The following is a description of a gene set: from publication Yevshin I, Sharipov R, Kolmykov S, Kondrakhin Y, Kolpakov F (PMID 30445619) Genes containing one or more binding sites for (E2F2) in their promoter regions (TSS -1000,+100 bp) as identified by GTRD version 20.06 ChIP-seq harmonization. species: Homo sapiens Human Gene Set: E2F2_TARGET_GENES, and this is the list of marker genes: PRRG2, OXSR1 (oxidative stress responsive kinase 1), KPNB1, METTL8, GANC, SAC3D1, SH3BP5L, COPS4, TOP2A, SNHG32, ITPRIPL2, CENPN, SNIP1, ELAC2, IMP3 (NCBI Gene Id 64970), KIF18A, CHMP7, MRM2, METTL2B, ELP5, PURB, MAP3K6, MAP3K11, SMC5, NCLN, NSL1, BTD, HRH1, EPM2AIP1, TNFRSF10A-DT, SIRT2, CLN3, B4GAT1, FGFR4 (NCBI Gene Id 2264), BCL3, SLC24A1, CACNA2D4, CSTF2T, HEPH, TLDC2, GNB2, SPATA41, UTS2B, RSRC2, PLEKHA6, UBE2B, USP37, TOMM20L-DT, SIL1, RNPEP, CASP8AP2, SEC31A, CDCA7L (NCBI Gene Id 55536), RPS6, PNISR, VTRNA1-2, DYNC2I1, MPZL3, RIMKLB, NIF3L1, NOL12, PAK4, ZNHIT2, FBXO33, MAST3-AS1, LRRC1, MLEC, AKT2, GLI1, CSNK1G3, ANK3, PRR5L, ALDH4A1, SNHG10, DCLRE1C, PPP2R1B, RPS12, ZNF747, HMGB2, RDM1P5, RPRD1B, EXOSC7, TSNAX, CDK1, NAA40, QRICH1, IRGQ, SIDT2, ATAD2, UQCC2, TUT1, SPRED2, SLC28A2-AS1, DDX41, C2CD3, TMPO, POLR1B, SPAG16-DT, RAB11B, HDGFL2, MFSD4B, TRAPPC9, DHPS, SYNGR4, GINS3, DDX39A, MSL1, CCDC47, UBXN8, INTS7, EDEM3, ATP10B, COMMD6, NOL8, BORCS8-MEF2B, TMC1, SRP54-AS1, GFM1, RNFT2, CDKL3, SH3BGRL3, TMA16, PDE8A, PPP1R11, HINT3, PLBD1, BAZ1B, RBBP4, ZMYM6, VTA1, CACTIN, CCNA2, DDX39B-AS1, CLSPN, ERP29, ACSS2 (acyl-CoA synthetase short chain family member 2), MKNK1, YARS2, RBBP5, CHAC1, TOP6BL, PSME2P3, CDH17, KAZALD1, CEP112, C6orf141 (chromosome 6 open reading frame 141), TMBIM6, CPEB4, RPL7L1P8, LSR, SRI, SLC25A23, CUTC, INPP5J, SNHG1, HACD2, MCM6, RPL26L1, POP7, TCF3, DDX11, FEM1A, MRPS31P4, TRIP4, RNF186-AS1, TRIM35, FASTKD5, SLC9A1, ABHD10 (abhydrolase domain containing 10, depalmitoylase), UBE2M, MCM5, DDIAS, HNRNPD, FTX, POLR2K, RBM14-RBM4, ASF1B, COX16, ZSCAN9, GAS2L1, UBL5, LINC00479, C19orf48P, CWC27, RGL2, BAHCC1, ANKHD1, MTMR9, SATB2, VPS72 (vacuolar protein sorting 72 homolog), HRCT1, LIM2-AS1, CEP63, NUTM1, FOXD1, ALKBH2, RFWD3, NR4A2, TSG101, POLR2M, RC3H2, RNASEK, PPP3CB, E2F2, ATF7, SEPTIN7-DT, GIRGL, NCAPG2, TDG, RPS7, CDIPT, TMC3-AS1, SLC4A1AP, B9D1, LRRC14, IDH3A, TNPO3, RWDD1, YAE1, OAS1, KBTBD4, PISD, TMEM79, THAP9, H2AZ2, CHCHD3, GAPDHP25, RPS25, AHCYL1, CDIPTOSP, NUP85, VPS33B-DT, IDH1, OGA, ARHGAP5, SYNCRIP, ZNF592, BRAT1, RPL21, TM4SF4, THAP9-AS1, PEF1, CMC2, SLC39A9, PSMD1, SNX8, TRAPPC4, PRPF40B (pre-mRNA processing factor 40 homolog B), BANF1, FBXO24, CCDC9, ETFBKMT, MPIG6B, NDC1, ITSN1, CKAP2-DT, RPL28, DCAF17, PDK2, OXA1L, ERH, FANCD2, MIGA2, STAM2 (signal transducing adaptor molecule 2), NUBPL, KLHL7, TICRR, AHRR, COQ6, GPRC5C, DPAGT1, TADA3, ZNF644, GOSR2, BRI3BP, SPC25, NSA2, SPATS2L, EIF3H, SPAG16, RPS6KA1, PHF14, PTPRZ1, RAB11A, IQCK, PROSER3, SUB1, MFAP3L, GON4L, TPM3, CHD9NB, DPH3, LTN1, CBY1, TMEM209 (NCBI Gene Id 84928), IMMP1LP1, HIBCH, ATR, TAF6L, CDKN2D (cyclin dependent kinase inhibitor 2D), EFNA3, C12orf76, PIK3C3, PXN-AS1, SLC2A8, GGA1, PIGW, BUB1B, EED, GABPA, EPCAM, SEMA3C, CLCF1, EME1, NCDN, DMRT2, GORAB-AS1, ING3, PTPN23, BRIX1, HSPB6, STAMBP, RCAN1 (regulator of calcineurin 1), PTBP1, SLC7A7, ZFAND6, PXMP2 (NCBI Gene Id 5827), ETV6, PRR11, ADAM9, H2AC15, LARP4, ARL6IP1, MIR3912, NFATC2IP, MCM4, SMIM31, TRBV30 (NCBI Gene Id 28557), SMG5, INTS2, PABIR1, GOLT1B, MYO15B, PBX1, HDGF, DNM1L, FAM156A, EXOSC2, PHLDA1-DT, CDK5RAP3, ELP6 (NCBI Gene Id 54859), MRPL17, WDR37 (WD repeat domain 37), RFXANK, RFC4, EWSR1, ZNF701, KIFC1, AKR1B10, DDX12P, DLG2, RNF39, BCL7B, MRTFA, KCNG3, PITX2, NUF2, TARS1-DT, RPS14, CCDC28A, TNFAIP8, RBM47, RIC8A, ENSG00000271860, MIX23, TMEM87A, NUBPL-DT (NCBI Gene Id 105370437), TLCD4, CSTF3, NVL, ROCK2, RIN1, ANP32E, ZNF213, HEXIM1, CENPE, YJU2, TMEM97 (NCBI Gene Id 27346), BRD8, ERI2, THG1L, TEX261, CEP295, PPP3CB-AS1, TCP11L2, TRA2B, RIF1, CLSTN1, POC1B-GALNT4, SLC35B1, LINC00339, ATM, RNU6ATAC, CSNK1D, SLC39A13, TSNAX-DISC1, BIN1, ZNF584, PPCDC, ZNF384, MIR4999, TNFRSF10B, MCFD2, DNAJC25, DLST, ZNF503, POU2F3, JUP (junction plakoglobin), MTMR9LP, NDRG1, CTDNEP1, LONP1, TPRA1, CENPF, SUPT5H, AP3S2, PHLDA1, HOXA-AS3, NPAT, SNORD26, AP4S1, PRR15, TXK, SLBP (stem-loop histone mRNA binding protein), TMEM126B, AIFM1, NDUFS3, PCLAF, DESI1, NIFK-AS1, NUMA1, TSLP, RPGRIP1L, LIPE-AS1, PJA2, TBL1X, TNRC6B, PANK3, TANK, FBXL5, C3orf38, LIPE, TOMM20L, MIA3 (NCBI Gene Id 440718), PPP4R3B, PPIG, NWD1, ARFIP1, CEP57L1, ACTMAP, MPP7-DT, NDUFA2, CASP7, UBE2I, NPRL2, SEC16B, NR2C2, LTBP1, POLR2B, HYAL2, RAD1, CIDECP1, PEF1-AS1, TTC1, AFF1, TIMM8A, UTP18, LINC01635, GTF2A1, LMAN2, PET100, SEPTIN7, SLC3A2, YWHAG, FTO, EMG1, HEG1, MCM7, AP3B1, GRIPAP1, RAF1, ZBTB22, LDHA, PPME1, PIGB, ARL14, HMGN1, IFT52, LGALS4, PIAS1, RN7SL346P, SUGP1, CYP2S1, POLD3, GINS1, CYRIB (NCBI Gene Id 51571), PHB2, GLIPR1L2, TBL1XR1, POT1-AS1, FRAT1 (FRAT regulator of WNT signaling pathway 1), MRPL27, STAG3L5P-PVRIG2P-PILRB, CEP97, FLCN, EHD2, EHD1, RPL10P15, KCTD20, HMBS, CDK12, H2AX, SMC2, TNFRSF10A, FAM174B, MRPL45P2, MED28-DT, DYNLRB2-AS1, ATL2 (NCBI Gene Id 64225), DUT, RNF128, ESF1, RPS26, TBC1D15, CCDC28A-AS1 (NCBI Gene Id 100507462), ENSG00000293341, ZCCHC8, KIAA0319L, VRK3, UBAP2L (ubiquitin associated protein 2 like), SP110, ARPC4-TTLL3, KIF3A, DPP3, QPCTL, PIN4, MED23, RAD54L, NUP42, ZNF747-DT, CAP2, SARM1, AKAP11, UQCR11, BET1L, RN7SK, COX7A2L, POLR3A, SCAMP1, PRCC, SP2-AS1, MTMR4, SPRY4, MLLT3, DUS4L, TMEM165, SRP54, EPB41L4A-AS1, MYO1A, CCNB1, AAGAB, RPL35, MDC1, RDH13, DBT, RBM15, MAT2B, TTC23, ENSG00000259182, ZNF799, ZNF687, GORAB, GDPGP1, COQ8B, EFHC1, C6orf52, STK31, MKKS, SLC30A4-AS1, VTRNA1-1, RYR3, SEMA4B, BCAS3, GRHL2, LRP4-AS1, MIR638, TMPRSS4, KRR1, SPC24, LINC03011, ZFYVE26, PRKCI, TTC13, NUDT9, MMS22L, LRRC23, MLH1, ARV1, DDX39B, MCM8, PDCD4, SFXN5, KIF20A, PFKM, UBL7-DT, LINC02756, IFT56, B4GAT1-DT, SUPT7L, RIOK3, EPCAM-DT, DOHH, EMC1-AS1, COX6B1, EVPL, DNAJC25-GNG10, FAM114A2, ALG14, TMX1, TBCCD1, MZT1, DHX34 (NCBI Gene Id 9704), RPL19, PTGES3, CDKN2C, SMG8, CLDN12, ARHGAP32, CDK5RAP2, HOMER1, LINC02205, RAD52, DTL, CNTRL, SERTAD1, NOP10, MYLK-AS1 (NCBI Gene Id 100873940), LAMA3, XAB2, SLC30A10, NCOA2, HTATSF1P2, CFAP20, DENND5B-AS1, ENSG00000239137 (novel transcript), AOC1, PCNX3, GCDH, RRM1, ATP5ME, CELSR3 (NCBI Gene Id 1951), JADE2, SNX1, CIMIP5, FAM200B, GOSR2-DT, DCTN1, PPP6R1, FBXL12, H4C4, OIP5-AS1 (OIP5 antisense RNA 1), CLPTM1, IPP, ATP8A1, EPG5, UBOX5, VPS50 (VPS50 subunit of EARP/GARPII complex), GMEB1, APOLD1, MED18, DCP2, REXO4 (REX4 homolog, 3'-5' exonuclease), HMGXB3, CCNI, LBR, RPLP0, NOSIP, NAP1L4, CD320, NUCKS1, TM2D1, BZW1, PKP3, SLC22A5, UBL7, LEMD3, RNF44, PSME3, PIK3R3, STXBP1, WASL-DT, ASB16-AS1, COL7A1, FDXR, CDC6, PIK3C2B, RSBN1, ZNF106, RPS29, RHEB, ADGRL1-AS1, GTF3C2-AS2, PEX16, LIMA1, MTMR14, SYT8, SREBF2, PPID, CDON, WDR36 (NCBI Gene Id 574015), TMT1A, RCHY1, BTBD10, FBXO9, RPS16, LINC01275, LRRC41, PPIC, CCNJL, SELENOW, COX15, BTBD19, ATF7-NPFF, ATP8A1-DT, MCTP2 (multiple C2 and transmembrane domain containing 2), GALE, GTPBP3, FCF1, TMC4, SLC36A1 (solute carrier family 36 member 1), COL4A2, RPL5, POLG-DT, FBXW7, CPOX, CCDC18-AS1, SNORA13, SSBP1, FRMD4B, SRRM5, ILK, TMEM167B, RHBDD3, MMAB, ELK4, H2AZ2-DT, EID1, XRCC6, HACD1, PRKRIP1, WASF2, PABPN1, MIA2-AS1, PPFIBP2, RGS20, EIF2S2, TLCD4-RWDD3 (TLCD4-RWDD3 readthrough), KCNIP2-AS1, XPO1, RPS9, ENPP3, FGD5-AS1, CRKL, KNTC1, LINC02615, LINC01431, ARPC4, HMGN2P46, NAXE, IGF2BP3, CGGBP1, ANKMY2, USF3, ZNF785, ATXN2, CENPT (NCBI Gene Id 80152), PPP1R37, NR5A2, GTF2A2, TRMT6, TARS1 (NCBI Gene Id 94887), UNC5B-AS1, PPM1L, CASD1, ILF3, BORCS8, NUP98, EIF2B5, HADHB, COPS5, MGME1, DNAJB11, RBM15-AS1, PLA2G6, ODAD3, RPAP1, LPCAT4, MAPK14, ZNF79, U2AF2, AP2S1, PIGBOS1, RGL1, PCLO, PCM1, KIF11, UQCC6, DYNLRB2, MIR3124, SNORA70, CSPP1, PRR7, TPI1P2, SKP1, SPTLC3, KPNB1-DT, PKP2 (plakophilin 2), PIBF1, AATF, ANKHD1-DT, METTL15, NAV1, PTPN21, ATOSB, GSTA4, RNU2-17P, MAP3K14, LINC00112, MRPL51, CLIP1, VPS4B, VARS2, BTAF1, SAE1, SELENOP, MYO19, CENPK, NUDT1, TMEM144, STAG3L5P, CEP120, EFCAB7, FBXO5, ANXA2, CRYZL1, SH2B1, USP36 (NCBI Gene Id 80160), METTL1, PHPT1, ZNF576, DIS3, NRP1, ARL1, PRPF4, COX5A, PLEK2, SHC4, ACO2, HSPA13, XPNPEP1, ENSG00000259403, ENC1, AP1M1, ANAPC13, MIA2, SMARCAL1, TRUB2, KRT8, OXA1L-DT, DNAAF3, ZNF271P, HNRNPD-DT, DDX3X, NKTR, OR10J2P, SRSF1, AURKB, NFKBIZ, ADAM11, DYNLT4, RFESD, RN7SL2, DYRK4, BORCS5, TEDC1, ZSCAN30, EOLA2, TRAJ7, GARS1, CENPP, ANKRD13A, ADAMTS7P4, INTS14, AGAP2-AS1, H2BC15, GFM2, FAM53C, SENP8, GTPBP1, NFIC, SLCO2B1, POLG, CDIN1, TM2D2, EXPH5, CCDC159, HEXIM2, SESN1, LINC03040, ENSG00000232995, CDC7, NEDD4, SPIN1, ZFYVE27, SNRNP200, TOPBP1, RBM14, TRAF3IP2 (TRAF3 interacting protein 2), C1orf21 (NCBI Gene Id 81563), DPP3-DT (DPP3 divergent transcript), C2CD5, DHDDS, SRCAP, MYL6B, ENSG00000187951, HACL1, C4BPB, RPL26, ENSG00000233461, IP6K2, PPP4R3B-DT, PCBP1-AS1, EOLA2-DT, RPP14, ZNF888-AS1, CLDN7, ARHGAP21, ZNF473, RAB10, ENSG00000265246, GHDC, PPP2R5B, SUN1, INTS4, EEF1AKMT3, KIF15, CDK13, WHAMM (WASP homolog associated with actin, golgi membranes and microtubules), MTOR, PRCP, ZNF823, IFT46, UPF2, FADS1 (fatty acid desaturase 1), SLC41A2, CPNE8, AHSA2P, B3GALNT2, UNC13D, NACA4P, ZNF250, MYO9A, HSD17B11, PTCH1, MGRN1, SNORD25, PRR5, CDK16, LINC02747, DMXL2, SLC25A30-AS1, GLO1, C9orf43, MICOS10, TMEM94, MYL5, PDP2, WDR55, SGTB, WBP2 (NCBI Gene Id 96240), GBA1, SREK1IP1, ATG2A, POT1, LINC00649, TPD52L2, TTI1, BZW2, OSBPL10, CAPS2, ELP3, PARK7, FHIT, CNOT9, RBM48, PRKCSH, SNX5, GEMIN2, SNRPD2, PRKDC, LINC02474, EMSY-DT, MROCKI, CTDSP1, DYNC2I2, ADGRE2, ANKHD1-EIF4EBP3, SPRING1, KDSR, UQCRH, PPM1L-DT, TMEM41B, CARNMT1, LRR1, SNORD101, TJP3, ASTE1, VPS26C, MTR, WDR54, PIK3R2, FCSK (NCBI Gene Id 197258), TIGD4, PSMC3, ZNF524, SART1, CLP1, TSPAN1, RNASEK-C17orf49, STXBP3, NAB2, C1orf43, DDX42 (DEAD-box helicase 42), PMS2P3, MCOLN1, MSH2, C2CD2L, ITPRIP, PUM3, LINC00511, ZNF213-AS1, HDAC5, HEXIM2-AS1, MAFF, SECTM1, RRN3, TLE4, MYL12A, PLEKHJ1, BCL6, AADACP1, NAGA, LARS1, INPPL1, NEIL1, ATAD3A, ISG20L2, LINC01342, SECISBP2L, UROS, TATDN3, TGFA, HTD2, ATG4C, PRSS16, SEC22C, PTPMT1, LRPPRC, USP48, GAS1RR, ERAP1, SF3A2, POLR2H, TIPIN, ACTN1, ZBTB8OS, LINC02926, ALCAM, TMEM260, RAB27A, RRAS, SLC35A3, EMC3-AS1, CENATAC, ALAS1, TLE1, CERK, CYB5RL, BORA (NCBI Gene Id 79866), TTF2, IQCG, CKAP5, STRN3, RN7SKP134, MPPE1, HSP90AB1, ENSG00000270174, RPTOR, MED28, STARD5, ZNHIT3 (zinc finger HIT-type containing 3), EPHB6, SPAG9, GCHFR, LINC02026, HOXA9, GTF3C2, IK, SLMAP, TMEM138, TENT2, EIF3B, SNORD27, MFAP3, ESR2, GTF2H4, CEP83, TBC1D32, PHF6, SLX4IP, NUS1, GALM, LINC02363, SKA2, SLC30A5, C12orf43, CDC37, LIN54, SNRPB2, RPS15A, FLAD1 (NCBI Gene Id 80308), KIFBP, SH3BGRL2, STIP1, CREB3L2-AS1, INCENP, TDP1, MVB12A, TNPO2, ASAH2B, BOLA1, ASXL1, ARHGAP11B-DT, LSM5, CD101-AS1, NOLC1, PCBP2, CSTF3-DT (NCBI Gene Id 338739), ST7L, CCDC28B, DDX11-AS1, NOA1, LOH12CR2, THAP11, EMSY, RND1, MICOS10-NBL1, DENND4A (DENN domain containing 4A), ARHGEF1, MTMR11, AP4M1, MAU2, GSPT1, ACCS, OCIAD1, OTULIN-DT, ERGIC2, PSMC3IP (NCBI Gene Id 51769), PLEC, LHX1, FAM200C, SKIDA1, MEA1, SPCS3, PRR14L, TMEM143, PGAP2, SNORD48, MYL6, MICAL3, CDC23, ANKRD17, ABCD3, ZNF774, TMEM219, PCSK9, WEE2-AS1, FERMT1, LDAH, MCM10, BBLN, TARDBP, FIZ1, NCOA4, TTC17, POP5, UQCC1, RIC8B, MFAP1, LFNG, PPWD1, LYRM2, ZNF564, CFLAR, HSD17B4, RFX1, MVK, ENAH, C19orf53, PHF23, NFATC4, GPRASP3, PLEKHA8, METTL2A, RALBP1, TUFM, G3BP2, CUL3, ALKBH7, GLRX5, SLC25A3, OXNAD1, ZNF503-AS2, VPS8 (VPS8 subunit of CORVET complex), LTB4R2, YAP1 (Yes1 associated transcriptional regulator), LRCH4, POC1B, ZNF180, ACAA1, TCEA1, SUCLG1, IQCH, SNORD84, ZFP90, PHB1, PPM1D, ADAMTSL5, HADHA, RNU6-92P, EPDR1, ZNF815P, PREPL, ARHGEF38, ARRDC4, DPH1, EIF1AD, UBE2N, FKBPL (FKBP prolyl isomerase like), SOCS5, COMT, SPINK4 (serine peptidase inhibitor Kazal type 4), CATSPERD, MTO1, MEF2D, GTF2IP7, AMN1, COQ4, SH3D21, NXN, NAGK, DHX30, RGS5, HSD17B12, MEIS1, DNM2, TMEM245, HJURP, OASL, FRS2, NCAPD2, RECQL, FAR1-IT1, NPM1, RIOK2, POC1A, TBX3, MIR8059, FXR2, RPL26L1-AS1, EBP, RHOQP1, CYB561A3, ZSCAN25, KIAA0825, NCAPD3, CLASP1, HMGB1, MED17, CCNG2, CYB561D2, MPHOSPH6, CEP44, TTC21B, EFCAB11, PKNOX1, CKAP2, KDM4B, VPS33B, EMC3, PTK2B, RPIA, DSG3, ZNRD2-DT, BMF, MFSD4B-DT, FZD1 (NCBI Gene Id 8321), DRAIC, WDR5, VPS13C, MGST3, TMEM14C, AVL9, ANGEL2, SLF1, METTL25B, PSIP1, ZNRD2 (zinc ribbon domain containing 2), TMEM248 (NCBI Gene Id 55069), CENPQ, PEX1, BECN1, UBR4, SMC3, SMARCAD1, MATR3, CDC26, PIWIL1, HROB, ANKRD40CL, WSB2, C1orf174, RPL35A, WDR5-DT, KIAA1586, NUFIP2, SENP1, ACP3, POU2F1-DT, PIGL, FBXO8, ESRP2, PIPOX, TMUB2, NR1D1, ATF2, HMGCR, POU2F1, LINC02739, TSPAN13, COMMD4, TPX2, USF1, FAF1, TOR3A, SCP2, SERINC1, CEP128, MACC1, RNU6-728P, MYRFL, ABCC5, TMPOP2, LINC00431, RBBP6, DCP1B, PHF12, ACAT2, REEP6, CDK7, CIAO2A, MIR933, SNRPA, PRORP, PIWIL2, PIKFYVE, STK35, MMADHC, STARD10, TANK-AS1, MANSC1, ALG2, CD2BP2, SCRN3, CMSS1, NR6A1, RBSN, CYB5B, WRAP53, PNPO, SEC61B, PCSK4 (proprotein convertase subtilisin/kexin type 4), ANXA1, ILF3-DT (NCBI Gene Id 147727), TEX2, NEMP1, ZNF133 (NCBI Gene Id 7708), CIC, CUL2, DCUN1D4, GPATCH4, ATP5PF, POU2AF1, SCEL, FAN1, TMSB4X, FAM227A, ATAD2B, KIAA1143, MMUT, CSNK2A1, NIBAN2, THAP6, NDUFAF5, SS18, VASP, CD2BP2-DT, FEZ2, PPIL3, PARS2, AOAH, KLHDC3, GPNMB, ATG101, XRCC5, CENPU, MRPL37, PKIB, SPRYD4, PAK1IP1, AREL1, INO80C, BCCIP, FOXP2, MRPL11, PRKAR1A, ID1, DCUN1D3, ZSCAN2, SMARCAD1-DT, ASB3, PPP2R3C, SLC25A53, FAM47E, ITGB5, PRR7-AS1, RPL22, CXCL2, COL17A1 (NCBI Gene Id 7828), OTUB2, AHCYL2, SF3A3, GNAL, PPOX, MIR194-1, DNAI4, PHF5A, MANF, ZNF320, DIAPH3, ENSG00000266401, MSL2 (MSL complex subunit 2), POLE3, CREBZF, R3HDML-AS1, ARPC5, LYRM1, GRHL2-DT, TMPO-AS1, KHSRP, NSUN6, MBTD1, ZNF484, TM4SF5, NFKBIB, VPS26B, H2AC12, ITGB3BP, FKBP14 (NCBI Gene Id 55033), LDAF1, MAP3K3, H4C1, ATF4, FADS2, CENPA, MAPK7, IDI1